The following is a description of a gene set: Mouse Gene Set: MIR_670_3P Genes predicted to be targets of miRBase v22 microRNA mmu_miR_670_3p in miRDB v6.0 with MirTarget v4 prediction scores > 80 (high confidence targets). from publication Chen Y, Wang X (PMID 31504780) species: Mus musculus, and this is the list of marker genes: Rbfox2, Prokr2, Paip2, Foxo4, Jade1, Zfp800, Dcaf10, Nt5c3, Trmt12, Crebrf, Wdr35, Slc25a4, Lgi1, Urm1, Macf1, Alcam, Cemip2, Paqr8, Eif4a2, Efnb2, Hook3, Pkp4, Ythdc2, Jade3, Nrip1, Nol12, Galnt13, Zfp235, Adora2a, Zcchc24, Pdgfb (platelet derived growth factor, B polypeptide), Enpp2, Lrp4 (NCBI Gene Id 277398), Chic1, Emilin3, Jag1, Phc3, Zfp606, Ccr5, Mettl14, Hinfp, Igfbp5, Uba1y, Astn1, Ncoa1, 2510009E07Rik, Tspyl5, Fam210a, Ccpg1, Pla2g12b, Nup50, Eif2s3x (eukaryotic translation initiation factor 2, subunit 3, structural gene X-linked), Arhgef33, Actr3, Rap2c, Ikzf2, Sycp2, Ak4, Fasl, Fbn2, Mageh1, Adarb2, Mesd, Id1, Wdr13, Zfp746, Dennd4a, Zfp866, Smim10l1, Ankrd44, Prpf4b, Cldn34b4, Rreb1, Fhip2a, P4ha1, Ttk, Evl, Rbfox1, Gm773, Iftap, Pikfyve, Mbtd1, Plxna2, Cxcl5, Dock4, Slc25a25, Sh3pxd2b, 1700129C05Rik, Kpnb1, Galnt4, Cab39 (calcium binding protein 39), Pou2f1, Rfx8, Lpcat2b, Ccdc82, Tmem170, Pcnt, Gem, Mrpl1, Radx, Fbxo8, Frzb, Zfp322a, Gabpb2, Cyp24a1, Spryd4, Armcx4, Kcnq2, Flacc1, Kdm6b, Trappc11, Clasp2, 4930571K23Rik, Cacul1, R3hdm1, Gcc2, Ralgapb, Cntn2, Hikeshi, Zfp719, Tmem263, Ivd, Cadm2, Ttc9c, Gtf2b, Ankrd17, Tafa1, P2ry10b, Tnks, Ankib1, Tmprss11d, Pcdh17, Fam136a, Slc28a3, Zfp329, Kat2b, Creb1, Apbb2, Bcl2l10, Cd44, Arhgap19, Rtn4, Gata6, Or51ab3, Celf3, Mplkip, Wt1 (NCBI Gene Id 319408), Gsk3b (glycogen synthase kinase 3 beta), Ppp1r3c, Kif26b, Gspt1, Zfp65, Mcm6, Chd6, Rbm47, Tlk2, Mlec, D430041D05Rik, Slc22a3 (NCBI Gene Id 20519), Ube2z, Pou3f2, Pate2, Aak1 (NCBI Gene Id 97341), Sema5a, Bcor, Ebf3, Ebf2, Ino80d, Agbl5, Sphkap, Cenpw, Kcnd3, Oxgr1, Zfp980, Ptprc, Ptprb, Elovl4, Tbl1xr1, Rabgap1l, Maoa, Oma1, Prrx1, AI429214, Lrrfip2, Plekha3